Given this list of marker genes Cln3, Cln6, Trem2, Manf, Tpp1, Ppt1, here is a description of the gene set: species: Mus musculus Binding to sulfatide, also known as 3-O-sulfogalactosylceramide, SM4, or sulfated galactocerebroside. Sulfatide is a class of sulfoglycolipid, which are glycolipids that contain a sulfate group. Mouse Gene Set: GOMF_SULFATIDE_BINDING